Given this list of marker genes NEU3, TREH, MANBA, NEU4, NEU1, MAN2B2, GM2A, LCT, HEXB, NEU2, MGAM, CTBS, GBA3, SI, MAN2C1, MAN2B1, here is a description of the gene set: The chemical reactions and pathways resulting in the breakdown of oligosaccharides, molecules with between two and (about) 20 monosaccharide residues connected by glycosidic linkages. species: Homo sapiens Human Gene Set: GOBP_OLIGOSACCHARIDE_CATABOLIC_PROCESS